Given this list of marker genes PLXNA1, FYN, CFL1, RAC1, PLXNA2, PAK1, PAK2, FES, SEMA3A, HSP90AB1, PAK3, LIMK1, HSP90AA1, NRP1, PLXNA3, PLXNA4, here is a description of the gene set: studied in species Homo sapiens Human Gene Set: REACTOME_SEMA3A_PAK_DEPENDENT_AXON_REPULSION Sema3A PAK dependent Axon repulsion